Given this list of marker genes VAV3, PTPRJ, CD53, HLA-DRA, ICAM1, CRACR2A, DUSP3, SCIMP (NCBI Gene Id 388325), CARD11, HAVCR2, MYH9, PRF1, CORO1A, SOCS6, LAT, SCRIB, STOML2, HLA-DRB1, NEDD9, LGALS3, ARHGDIA, NPTN, RHOH, CD81, CD3E (NCBI Gene Id 916), ATP2B1, CD28, STX7, SKAP1, FYB2, CD6, LCK, ZAP70, PRKCQ, DLG1, PDCD6IP, ALCAM, CALHM6, PRKAR1A, EZR, IL4I1, GZMB, CD37, CRTAM, BCL10, GZMA, SNX27, CARD10, here is a description of the gene set: studied in species Homo sapiens An area of close contact between a lymphocyte (T-, B-, or natural killer cell) and a target cell formed through the clustering of particular signaling and adhesion molecules and their associated membrane rafts on both the lymphocyte and the target cell and facilitating activation of the lymphocyte, transfer of membrane from the target cell to the lymphocyte, and in some situations killing of the target cell through release of secretory granules and/or death-pathway ligand-receptor interaction. Human Gene Set: GOCC_IMMUNOLOGICAL_SYNAPSE